The following is a description of a gene set: studied in species Mus musculus Mouse Gene Set: GOBP_CHORIO_ALLANTOIC_FUSION The cell-cell adhesion process in which the cells of the chorion fuse to the cells of the allantois., and this is the list of marker genes: Itga4 (integrin alpha 4), Lef1, Wnt7b, Zfp36l1, Vcam1, Bmp5, Dnajb6, Erf, Bmp7, Ccn1